Given this list of marker genes RHOC (ras homolog family member C), EXTL2, FBXO33, NEK1, FKBP3 (NCBI Gene Id 2287), RWDD2B, ALDH3A2, TMEM47, RPL9 (ribosomal protein L9), HAUS4, RABGGTB, EEF1A1, MBNL1, NIBAN1, PTEN, PHTF2, FNDC3A, ID2, MACROH2A2, RASIP1, FERMT2, ALOX5AP, CCP110, BCL2L2, PDGFD, MRPS25, TUBGCP3, CGRRF1, NOP53, PTPRN2, SCAF11, RPF2, COX6A2, CLK4, ATR, SPART, CAST, PNMA1, ERMAP, CWC27, here is a description of the gene set: Human Gene Set: EHLERS_ANEUPLOIDY_UP species: Homo sapiens Up-regulated genes in the expression signature of aneuploidy in uveal melanoma tumors: low vs high aneuploidy. from publication Ehlers JP, Worley L, Onken MD, Harbour JW (PMID 18172260) PURPOSE: Aneuploidy is a hallmark of cancer and is closely linked to metastasis and poor clinical outcome. Yet, the mechanisms leading to aneuploidy and its role in tumor progression remain poorly understood. The extensive and complex karyotypic abnormalities seen in many solid tumors could hinder the identification of pathogenetically relevant chromosomal alterations. Uveal melanoma is an attractive solid tumor for studying aneuploidy because it is a relatively homogeneous cancer that is highly metastatic and has low nonspecific chromosomal instability. EXPERIMENTAL DESIGN: Comparative genomic hybridization and gene expression profiling were used to analyze patterns of aneuploidy in 49 primary uveal melanomas. This analysis was supplemented by a review of cytogenetic findings in 336 published cases. RESULTS: Three prognostically significant tumor subgroups were identified based on the status of chromosomes 3 and 6p. Discrete patterns of chromosomal alterations accumulated in these three subgroups in a nonrandom temporal sequence. Poor clinical outcome was associated with early chromosomal alterations rather than overall aneuploidy. A gene expression signature associated with aneuploidy was enriched for genes involved in cell cycle regulation, centrosome function, and DNA damage repair. One of these genes was PTEN, a tumor suppressor and genomic integrity guardian, which was down-regulated in association with increasing aneuploidy (P = 0.003). CONCLUSIONS: The relationship between aneuploidy and poor prognosis may be determined by specific, pathogenetically relevant chromosomal alterations, rather than overall aneuploidy. Such alterations can be identified using integrative genomic methods and may provide insights for novel therapeutic approaches.